Given this list of marker genes TRMT2A, NOP2, NSUN5, NSUN4, TRMT2B, COQ5 (NCBI Gene Id 84274), here is a description of the gene set: Human Gene Set: GOMF_C_METHYLTRANSFERASE_ACTIVITY Catalysis of the transfer of a methyl group to the carbon atom of an acceptor molecule. species: Homo sapiens